Given this list of marker genes PHKG2, TRMU, GYG1, MT-TE, MSTO1, PHKA1, GYS1, PFKM, PHKG1, GAA, PHKB, ENO3, PYGM (glycogen phosphorylase, muscle associated), PHKA2, here is a description of the gene set: studied in species Homo sapiens Abnormal muscle glycogen content Any anomaly in the amount of glycogen in muscle tissue. Human Gene Set: HP_ABNORMAL_MUSCLE_GLYCOGEN_CONTENT